The following is a description of a gene set: species: Homo sapiens Catalysis of the reaction: leukotriene C4 + a standard alpha amino acid = leukotriene D4 + an (gamma-L-glutamyl)-L-amino acid. Human Gene Set: GOMF_LEUKOTRIENE_C4_GAMMA_GLUTAMYL_TRANSFERASE_ACTIVITY, and this is the list of marker genes: GGT7, GGT1, GGT5, GGT3P, GGT6